The following is a description of a gene set: electronically inferred by orthology from the curated human pathway Reactome Pathway: Conversion from APC/C:Cdc20 to APC/C:Cdh1 in late anaphase This event has been computationally inferred from an event that has been demonstrated in another species.<p>The inference is based on the homology mapping from PANTHER. Briefly, reactions for which all involved PhysicalEntities (in input, output and catalyst) have a mapped orthologue/paralogue (for complexes at least 75% of components must have a mapping) are inferred to the other species. species: Mus musculus part of: APC/C-mediated degradation of cell cycle proteins, and this is the list of marker genes: Cdc23, Ube2s, Ube2c, Cdc26, Fzr1, Anapc10, Ube2e1, Anapc2 (anaphase promoting complex subunit 2), Anapc7, Ube2d1, Cdc14a, Anapc15